The following is a description of a gene set: species: Homo sapiens Human Gene Set: HP_THICK_HAIR Thick hair Increased density of hairs, i.e., and elevated number of hairs per unit area., and this is the list of marker genes: NEK1, ZFX, NDUFAF6, KCNK4, ATP6V1E1, INSR, ATP6V1A, ATP6V0A2, COG4, KMT2A (NCBI Gene Id 79951), RUSC2, KCNN3, AFF4, CLDN1, VPS13B, KCNH1, ATP7A, ASXL1, MSTO1, SMC3, VPS33A